The following is a description of a gene set: The inability to close the eyelids during sleep. Nocturnal lagophthalmos Human Gene Set: HP_NOCTURNAL_LAGOPHTHALMOS species: Homo sapiens, and this is the list of marker genes: DNMT3B, FRG1, LMNA, SMCHD1, DUX4L1, ZMPSTE24, DUX4